Given this list of marker genes ARHGEF15, CCNB2, BACE2 (beta-secretase 2), MAPK13, ESR1, SOX9, PRKCD, YWHAZ, GRB7, PIK3C3, ARPC5L, GADD45A, CDKN2A, HNF4A, PDGFRB, WEE1, CLDN4, SMAD5, PLCB1, DUSP1, SEMA3C, LINGO1, MAP3K5, RARG, DKK1, FGFR3, FZD5, ASAP1, MAP2K2, GYS2, CYCS, MERTK, BAK1, ITGB5, CLDN2, MYLK, CSNK1E, PIK3C2G, DDR1, MMP11, ELF3, TCF7L2, SEMA4G, IGF1, UBD, ROBO2, CLDN1, here is a description of the gene set: Human Gene Set: YAMASHITA_LIVER_CANCER_STEM_CELL_UP Genes up-regulated in hepatocellular carcinoma (HCC) cells with hepatic stem cell properties. BACKGROUND & AIMS: Cancer progression/metastases and embryonic development share many properties including cellular plasticity, dynamic cell motility, and integral interaction with the microenvironment. We hypothesized that the heterogeneous nature of hepatocellular carcinoma (HCC), in part, may be owing to the presence of hepatic cancer cells with stem/progenitor features. METHODS: Gene expression profiling and immunohistochemistry analyses were used to analyze 235 tumor specimens derived from 2 recently identified HCC subtypes (EpCAM(+) alpha-fetoprotein HCC and EpCAM(-) AFP(-) HCC). These subtypes differed in their expression of AFP, a molecule produced in the developing embryo, and EpCAM, a cell surface hepatic stem cell marker. Fluorescence-activated cell sorting was used to isolate EpCAM(+) HCC cells, which were tested for hepatic stem/progenitor cell properties. RESULTS: Gene expression and pathway analyses revealed that the EpCAM(+) AFP(+) HCC subtype had features of hepatic stem/progenitor cells. Indeed, the fluorescence-activated cell sorting-isolated EpCAM(+) HCC cells displayed hepatic cancer stem cell-like traits including the abilities to self-renew and differentiate. Moreover, these cells were capable of initiating highly invasive HCC in nonobese diabetic, severe combined immunodeficient mice. Activation of Wnt/beta-catenin signaling enriched the EpCAM(+) cell population, whereas RNA interference-based blockage of EpCAM, a Wnt/beta-catenin signaling target, attenuated the activities of these cells. CONCLUSIONS: Taken together, our results suggest that HCC growth and invasiveness is dictated by a subset of EpCAM(+) cells, opening a new avenue for HCC cancer cell eradication by targeting Wnt/beta-catenin signaling components such as EpCAM. from publication Yamashita T, Ji J, Budhu A, Forgues M, Yang W, Wang HY, Jia H, Ye Q, Qin LX, Wauthier E, Reid LM, Minato H, Honda M, Kaneko S, Tang ZY, Wang XW (PMID 19150350) studied in species Homo sapiens